The following is a description of a gene set: species: Homo sapiens Murine Cytomegalovirus (MCMV) infection leads to early activation of various immune cells, including B and T lymphocytes, before the actual initiation of antigen-specific adaptive immunity. This activation is partly driven by innate cytokines, including type I interferon (IFN), which are induced early after infection. The objective of this study was to address the role of type I IFN in shaping early/innate B and T cell responses to a primary acute viral infection. In order to decipher the specific impact of IFN-I on cell subsets, we performed a genome-wide expression analysis on WT splenic B and CD8 T lymphocytes isolated from C57BL/6 mixed bone marrow chimera mice. This study complements series GSE39555, which focused on early responses of NK cells and of the two subsets of conventional dendritic cells. Human Gene Set: GSE45365_CD8A_DC_VS_CD11B_DC_IFNAR_KO_MCMV_INFECTION_UP Genes up-regulated during primary acute viral infection in dendritic cells: CD8A versus ITGAM+., and this is the list of marker genes: APEX1, OXA1L, SLC25A15, DDX18, MTMR4 (myotubularin related protein 4), KIF4A, DDX31, MID2, TBX3, CDH7, HNRNPK, PMS2P11 (NCBI Gene Id 107161145), NKX3-2 (NCBI Gene Id 579), ATP6V0E2-AS1, TCHH, PCBP1-AS1, ID2, POLR1HASP, KDM3A, FANCC, FAM53B, COPA, FOXG1, ANP32A, NIFK-AS1, CFAP107, PRUNE1, GARIN5B, DAP, KREMEN2, LINC01016, FOXN3, RBM27, PNMT, CRKL, PRM3, SLC25A11, DDX6, BMP7, SCGN, DEDD, CFDP1, CYP4F30P, DOK4, FBXL8, TMEM35A, IL27, HHIP-AS1, BORCS5, UGGT2, FKBPL, KRT86, GRIPAP1, C8orf34-AS1, DRD4, GPIHBP1, SLC2A3, SOX13, PPP1R27, BCL2L11, DHX38, HOXA11, MIA2, PTCH1, NOD2, ROR2, FAM3B, WNT7A, KRT80, LINC02579, HOXA5, RBFOX3, PLEKHO1, SYCP2 (NCBI Gene Id 10388), TOLLIP, POF1B, PATE2, ZNF34, BMS1, BCORP1, NCAM1, MOB3C, RELCH, HNRNPU, TARS3, LRP2, TGIF1, HJURP, ACTR1A, MYLIP, RGMB, GET1, SUPT16H, CD300C, PHF7, H2AC15, GK3, TAB1, WASHC5, KLHDC8A, RAF1, TMEM230, PPP5C, CTSH, SLC25A19, LILRB5, FOXD3, CPO (carboxypeptidase O), KLRB1, MIR924HG, SETD6, NCAPH, FGF9, SP5, SMIM10, NFATC4, PCSK1, MMS19, MAPRE2, ZNF606, SNX9, EVX1, C2orf68, AIFM1, MIR34BHG, ZBED3-AS1, IL36A, TRAT1, H1-5, ZNF71, SST, EIF1 (NCBI Gene Id 1963), RALGAPB, LUZP1, COLEC10, LINC01134, MAB21L1, CCND1, PPARGC1A, PITRM1, ACAA2, GABRA4, PRKAR2B, DCAF10, KIF14, NOTCH1 (NCBI Gene Id 54781), NFS1, SNX30, GGT7, LY6G5C, COPS7A, ADGRF4, SNX1, BLMH, SLC25A20, ISG20 (interferon stimulated exonuclease gene 20), BRK1, PPP1R14A, PPP1R3E, UBL4A, ERCC6L2-AS1, KIF23, SELENBP1, ARL2, FAM169A-AS1, OSBPL3, ARMCX1, ABCF3, IGF2R, LRRC75A, SOX9-AS1, KIAA0586, TCF20, ANKFY1, TATDN2, RMST, WDR70, AKR1C4, LHFPL6, CLIP2, TMEM87B, DDIT4, ZFP82, CLYBL, PUDP, ALKBH6, RPRM, ALDH7A1, ENSG00000286546, MAS1, CHGA, RAX, SKIDA1, CEP83-DT, GID8, ALDH1A3, MARK3 (NCBI Gene Id 4140), DOCK10